Given this list of marker genes PSME3IP1, SLC12A3, MT1A (NCBI Gene Id 81835), MT1CP, RSPRY1, HERPUD1, AMFR, NLRC5, PLLP, NUP93-DT, MT1L, BBS2, MT1JP, OGFOD1, MT3, GNAO1-DT, NUP93, MT2A, MIR138-2, MT1DP, NUDT21, CPNE2, GNAO1, CPNE2-DT, MT1IP, DPPA2P4, MT1B, MT1F, MT1G, MT4, RPS24P17, MT1M, MIR3935, MT1E, ARL2BP, MT1H, CFAP69P1, CETP, MT1X, MIR6863, here is a description of the gene set: Human Gene Set: chr16q13 studied in species Homo sapiens